Given this list of marker genes Lonrf2, Sod1, Jun, Cdk5r1, Tmbim4, Retreg1, Gata3, Sncb, Fgf2, Gch1, Il6, Pik3ca, Crlf1, Nf1, Msh2, Il6st, Hif1a, Rnu12, Alkbh1, Fgf20 (fibroblast growth factor 20), Casp4, Pycr1 (NCBI Gene Id 209027), St8sia2, Ncf2, Foxb1, Tnfrsf1a, Fgf8, Lgmn, Xrcc2 (NCBI Gene Id 80583), Sct, Braf, Nono, Casp12, Fasl, Cdc42, Rhoa, App, Ptpn5, Kdr, Epor, Adam8 (a disintegrin and metallopeptidase domain 8), Nr4a2, Park7, G6pd2, Bcl2l1, Ppp2r2b, Ascl1, Vegfa, Bcl2l11, Tnf, Tfap2b, Hdac3, Kcnma1, Zpr1, Ntrk2, Mt3, Vps54, Mfsd8, Nox1, Stxbp1, Hras, Hdgf, Hrk, Pin1 (NCBI Gene Id 67670), Rad21, Ntrk1, Slc25a27, Cntf, Ppargc1a, Nrbp2, Arrb2, Cx3cr1, Ddit3, Ambra1, Casp6, Tert, Akt1s1, Cln8, Casp14, Esr2, Syngap1, Six1, Grn, Nsmf (NCBI Gene Id 56876), Prodh, Ube2v2, Mcl1, Oxr1 (oxidation resistance 1), Barhl1, Ntf3, Stambp, Faim2, Sirt1, Ubb, Optn, Nos1, Egr1, Aimp2, Atf4, Clcf1, Gfral, Mir124a-1, Tox3, Dnajc5, Sod2, Cx3cl1, Agtr1b, Nfatc4, Hyou1, Prdx2, Ager, Il18 (NCBI Gene Id 16173), Slc1a1, Kcnb1 (potassium voltage gated channel, Shab-related subfamily, member 1), En2, Cited1, Egln2, Srpk2, Egln3, Cdk5, Cpeb4, Aars1, Casp8, Bdnf, Esr1, Hmox1, Glp1r, G6pdx, Grina, Ccr5, Pcdhgc5, Map2k4, F2r, Mecp2, Nmnat1, Ndnf, Gclm, Lrp1, Hdac4, Adora2a, Gsk3a, Grik2, Npm1, Snca, Amigo2, Thap11, Pink1, Pak3, Ucn, Wfs1, Mmp2, Mdk, Rock1 (NCBI Gene Id 68785), Isl1, Apoe (apolipoprotein E), Parp1, Ptk2b, Pin1rt1 (peptidyl-prolyl cis/trans isomerase, NIMA-interacting 1, retrogene 1), Snx6 (sorting nexin 6), Kif14, Casp7, Trp73, Gba1, Trp53, Prkn, Agap2, Crhr1 (NCBI Gene Id 12921), Bbc3, Pcp4, Tyro3, Mybl2, Myb, Cdc34b, Sarm1, Cacna1a, Atf2 (activating transcription factor 2), Map3k12, Agtr1a, Kdm2b, Ptprz1, Fgfr3, Smo, Atp7a, Nupr1, Prdx3, Lcn2, Aifm1, Pitx3, Map2k7, Bhlhb9, Fyn, Fxn, Sigmar1, Bbs10, Grm7, Ngfr, Jak2, Musk, Ccl12, Agt, Ube2m, Cblc, Pou4f1, Traf7 (TNF receptor-associated factor 7), Htt, Agtr2, Cdc34, Adnp, Wnt1, Epha4, Tmbim1, Btg2 (NCBI Gene Id 98237), Tfap2a, Prkcg, Cebpb, Ilk (NCBI Gene Id 16202), Pcdhgc3, Star, Tgfb3, Xrcc4, Trem2, Mt1, Ppt1, Gpi1, Nqo1, Prnp, Gdnf, Pdpk1, Epha7, Bax, C5ar1, Arrb1, Nrp1, Fis1, Gbe1, Nefl, Axl, Plxnd1, Xiap, Il10, Grid2, Mapk8, Trim2, Clu, Nr3c1, Fbxo7, Itga1, Mtor, Vstm2l, Chl1, Nfix (nuclear factor I/X, NCBI Gene Id 18032), Ngf, Agrn, Fas, Ripk1, Fbxw7, Gclc, Grik5, Casp3, Bok, Pla2g3, Kras, Atm, Coro1a, Grin1, Tfap2d, Birc5, Fzd1, Foxq1, Pcsk9, Unc5b, Atg7, Itsn1, Il27ra, Cntfr, Mdga2, Draxin, Prkci, Ctnnb1, Casp9, Cln3, Ntf5, Pmaip1, Vegfb, Six4, Mag, Gdf5, Bace1, Foxo3, Map3k11, Lig4, Ucp2, Gsk3b, Cflar, Abl1 (NCBI Gene Id 98922), Nr4a3, Casp2, Fmr1, Ccnd1, Erbb3, Egln1, En1, Psen1, Nes, Nppc, Htr2a, Nqo2, Mef2c, Adcy10, Il1b, Pawr, Hsph1 (heat shock 105kDa/110kDa protein 1), Bcl2, Grk1, Dlx1, Sema3e, Rapsn, Pcdhgc4, Angpt1, Mtnr1b, Hspd1 (NCBI Gene Id 15510), Fzd9, Phb1, Cd2ap, Bag1, Hipk2, Tgfb2, Hsp90ab1, Kcnip3, Fcgr2b, Ptprf, Ccl3, Set, Nae1, here is a description of the gene set: Mouse Gene Set: GOBP_REGULATION_OF_NEURON_APOPTOTIC_PROCESS studied in species Mus musculus Any process that modulates the occurrence or rate of cell death by apoptotic process in neurons.